The following is a description of a gene set: Human Gene Set: GOBP_REGULATION_OF_SYNAPTIC_VESICLE_MEMBRANE_ORGANIZATION studied in species Homo sapiens Any process that modulates the frequency, rate or extent of synaptic vesicle membrane organization., and this is the list of marker genes: SYT13, GRIK5, ERC2, CPLX4, SYT9, SYT1, SYT4, CPLX2, RAB3A, DOC2A, PRRT2, SYT5, SYT8, STXBP1, CPLX1, SYT2, RPH3A, RPH3AL, SYT7, CPLX3 (NCBI Gene Id 594855), SYT11, DOC2B